Given this list of marker genes Ush1c, Pou4f1, Sox2, Rubie, Ush1g, Pcdh15, Cdh23, Myo7a, Ankfn1, Clrn1, here is a description of the gene set: Mouse Gene Set: GOBP_EQUILIBRIOCEPTION The series of events required for an organism to receive an orientational stimulus, convert it to a molecular signal, and recognize and characterize the signal. Equilibrioception refers to a combination of processes by which an organism can perceive its orientation with respect to gravity. In animals, stimuli come from labyrinth system of the inner ears, monitoring the direction of motion; visual stimuli, with information on orientation and motion; pressure receptors, which tell the organism which body surfaces are in contact with the ground; and proprioceptive cues, which report which parts of the body are in motion. studied in species Mus musculus